The following is a description of a gene set: studied in species Mus musculus Leptin and adiponectin Mouse Gene Set: WP_LEPTIN_AND_ADIPONECTIN, and this is the list of marker genes: Adipor2, Lep, Acaca, Prkag1, Prkaa1, Adipor1, Lepr, Adipoq, Cpt1a, Prkab1